Given this list of marker genes RNH1, TRAPPC11, MECR, TBX1, KIDINS220, HOXB1, AFF4, HACE1, SCN8A, GJA5, GJA8 (NCBI Gene Id 2703), here is a description of the gene set: Heterophorias are latent deviations that are controlled by fusion. In certain circumstances (specific visual tasks, fatigue, illness, etc.), fusion can no longer be maintained and decompensation occurs. Heterophoria species: Homo sapiens Human Gene Set: HP_HETEROPHORIA